Given this list of marker genes Nf1, Mettl23, Ttbk1, Camk2n1, Grm7, Grpr (NCBI Gene Id 14829), Grin1, Atp1a3, Fgf13, Dbi, Clstn2, Ppp1r9b, Eif4ebp2 (NCBI Gene Id 69229), Ulk4 (unc-51-like kinase 4), Dgcr2, Prkca, Nsun5, Mfsd2a, Tmod2, Deaf1, Ric8a, Taar5, Slc6a3, Dcdc2a, Tbr1, Musk, Th, Foxo6, Jph4, Chrm1, Slc12a5, Ptgs2, Hif1a, Pianp, Egr1, Vip, Rag1, Map1a, Ptn, Pafah1b1, Foxp2, Gabra5, Atad1, Ppp1r1b, Lmx1b, Nptx2, Dnah11, Nr4a2 (nuclear receptor subfamily 4, group A, member 2), Asic1, Il1b, Slc8a2, Cic, Glud1, Itga8, Hrh1, Adgrf1, Adam2, Shank2, Tlr2, Chrnb2, Atp1a2, Ucn, Abca7, Neurog1, Specc1, Lhcgr, Taco1, Ncstn (NCBI Gene Id 68116), Syt11, Ncam1, Prkar2b, Shc3, Nrxn3, Cyp7b1, Bace1, Btg2, Pak6, Ift20, Hrh3, Abi2, Ube3a, Ankrd11, Slc1a4, Nrxn1, Gm527, Pak5, Lgmn, Rogdi, Aff2, Cdk5, Adcy8 (adenylate cyclase 8), C1ql1, Tifab, Meis2, Cux2, Il1rn, Snap25, Zfp385a, Igf1, Gatm, Amfr, Ghrl, Aph1b, Crh, Oxt, Amph, Slc1a1, St3gal4, Atxn1l, Drd5, Grcc10, Ngf, Zzef1, Csmd1, Tacr1, Plcb1, Pde1b, Gm2a, Crhr1, Cln8, Eif2ak4, Pak1, Dgki, Abl1, Bche, Slc17a7, Oprl1, Casp3 (caspase 3), Tusc3, Crtc1, Gmppa, Mme, Mecp2, Picalm, Adgrb3, Ndrg4, Drd4, Rgs14, Adrb1, Gucy2d, Pln, Casp1, Lrrn4, Hmgcr, Chat, Mapt, Slc2a4, Fzd9, Psen2, Trpm7, Foxb1, Tmprss11e (transmembrane protease, serine 11e), Nipbl, Epm2a, Cck, Nlgn3, Tacr2, Pde5a, Srf, Elavl4, Nfatc4, Drd1, Egfr, Fen1, Kcnab1, Itga5, Htt, Man2b1, Tafa2, Ntrk2, Adora1, Lins1, Cx3cr1, Tpbg, Cln3, Lmx1a, Pias1, Pla2g6, Gmfb, Bglap2, Pirb, Dtnbp1, Prnp, Aph1c, Bloc1s6, Nrg1, Apoe, Dnaaf4, Clstn3, Ntrk1, Htr6 (5-hydroxytryptamine (serotonin) receptor 6), Ptgs1, Ptchd1, Aaas (achalasia, adrenocortical insufficiency, alacrimia), Gpr155, C5ar1, Sorcs3, Mup20, Adcy3, Gnas, Prrt1, Calb1, Ccnd2, Nts (NCBI Gene Id 67405), Stra6, Igf2, Cacna1e, Tac1, Pgrmc1, Vps13b, Kcnk2, Ccl11, Gpr88, Kat2a, Htr2c, Slc7a11, Synpo, Bdnf, Mef2c, Htr2a, Sct, Cacna1c, Ndufs4, Gria1, S100b, Arc, Washc4 (WASH complex subunit 4), D130043K22Rik, Rtl4, Lamb1, Hrh2, Psen1 (NCBI Gene Id 19164), Or52b4, Ythdf1, Shank3, Sobp, Glp1r, Cntn2, Slc24a2, Kctd16, Agt, Spg11, Sgk1, Nptn, Plk2, Pax6, Pomk, Cnr1, Arf4, App, Thra, Ddhd2, Grm4, B2m, Crebbp, Lhx8, Kras, Neurod2, Kcnq2, Ptprz1, Dkk1, Comt, Shroom4, Rin1, Mgat3, Chrna4, Bglap, Cc2d1a, Rcan1, Cbr3, Hoxa1, Or52b4i, Kalrn, Ntan1, Acss2, Ldlr, Uba6, Rps6kb1, Synj1, Chmp2b (charged multivesicular body protein 2B), Paip2, Braf, Rcan2, Mdk (midkine), Chst10, Ager, Chl1, Trem2, Neto1, Atxn1, Tnr, Ctns, Tanc1, Ttc36, Htr7, Mtor, Rp9, Camk4, Prkn, Oxtr, Npas4, Prkcz, Reln, Adra1b, Slc6a4, Adrb2, Chrd, Garem2, Vdac3, Pde8b, Gtf2a1l, Egr2, Ap1s2, Oprk1, Vdac1, Magt1, Chrna7, Sts, Jph3, Ctnnd2, Tuba1a, Fos, Gpr158, Dop1b, Creb1, Pja2, Pten, Dcaf11, Pde4d, Large1, Ep300, Kmt2a, Ghsr, Shank1, Nog, Atp8a1, Drd3, Pdcd10 (programmed cell death 10), Brinp1, Gip, Chd7, Ephb2, Cpeb3, Cyfip1, Prkar1b, Abl2, Jakmip1, Kit, Ckap5, Drd2, Shisa7, Brsk1, Grin2b, Fosl1, Grin2a, Mapk8ip2, Aldh1a7, Slc11a2 (NCBI Gene Id 18174), Abcc8, Nrxn2, H2-Ea (histocompatibility 2, class II antigen E alpha), Itga3, Slitrk4, Nedd9, Git1, Rapgef3 (Rap guanine nucleotide exchange factor (GEF) 3), Ppt1, Syt4, Syngap1, B3gat1, Tsc1, Grm5, Slc8a3, Setd5, Abcc1, Serpinf1, Jun, En1, Fam107a, Dbh (dopamine beta hydroxylase), Btbd9, Gpi1, Klk8 (kallikrein related-peptidase 8), Nfix, Trpm4, Kat2b, Src, Gabrb3, Adnp, Prkcg, Slc6a1, Lcn2, Itgb1, Ehmt2, Adcy1, Scn2a, Ntsr1, Bhlhb9, Nps, B4galt2, Ntf5, Cntnap2, Itpr3, Arl6ip5, Idua, Esr2, here is a description of the gene set: Mouse Gene Set: GOBP_COGNITION The operation of the mind by which an organism becomes aware of objects of thought or perception; it includes the mental activities associated with thinking, learning, and memory. studied in species Mus musculus